Given this list of marker genes WT1-AS, CDIPT (CDP-diacylglycerol--inositol 3-phosphatidyltransferase), GRIN2D, C22orf31, ADAMTS1 (NCBI Gene Id 9510), VCP, CDKN1A, NUDC, ACVR1, STK40, UNC45B, OLFML1, TMEM138, TSBP1, RAB24, EPB41L1, STAT4, EWSR1, FGF16, CDK5R2, JARID2, FBXO30, DNAJB5, BEST3, INTS2, MYOD1, CEP164, ATP6V0D2, TOP6BL, SGMS2, NTF4 (NCBI Gene Id 4909), LRRC17, ZBTB32, TLK1, PRDX6, DNAJB2, RIMS2, MAPT, HAT1, E2F1, MORF4L2, KRT26, SPACA3, CEPT1, TMPRSS11A, MYT1, CXXC4, PLAT, CD274, ATP5ME, KCNH2, C4orf17, HSPH1, CYP39A1, SPTLC3, PNCK, SPATA17, GPX1, PDP1, AZIN1, SLC4A2, LIX1, TWIST2, KRIT1, SAG, NCKAP5, CCN1, KCNQ1, GPATCH2, ESR1, EMX2, RALYL, SELP, CHORDC1, SPMIP6, PWWP3B (NCBI Gene Id 139221), TSPAN6, MTPN, NPPB, IL2, GABRB1, RAB2B, PROM1, NUP98, JMJD6, MEGF10, IER5, STIP1, HMBOX1, WNT3, LYRM1, MGAT3, NRGN, ACOT7, TOP1, HSPB1, STAG2, GTF3C2, CCT4, ZNF436-AS1, EIF5B, TLR8, PTRH2, DCUN1D3, CAP1, FAM106A, TGIF1, TNMD, YWHAG, LGSN, EFHD1, STAMBP, LMOD1, IL34, MED26, IMMP1L, RHBDD3, SERPINH1, TEDC1, ELP4, RNFT1, PPP1R7, SERPINA10, JAG1, UPF2, FLRT1, ETV1, GRK2, PTHLH, IL21R, ABL1, ZNF407, ELOVL1, XPNPEP3, RFTN2, PTGDS, COG7, GJB6, MEIOB, TAS2R5, MLLT11, MAP3K6, PCDH8, EGR2, AIFM3, KRT20, ZNF593, BCL6, ABCA3, PER2, TPP2, PKN1, HSPD1, RTN1, VWA1, IL22RA2, CCDC117, APLP2, C1orf105, AP3D1, NETO1, CYB561A3, KLHL9, CNIH1, BRD2, PRDM2, ABTB3, GPR22, CLDND2, CDK5, HSPB2, CYP46A1, DERL3, DMRTB1, LTC4S (NCBI Gene Id 4056), SIX3, EVC2, ST13, RFLNB, CELF3, CCDC6, CRYAB, YIPF4, HSPA8, ARSG (NCBI Gene Id 22901), PNKD, SDHAF4 (succinate dehydrogenase complex assembly factor 4), MAST1, SATB2 (NCBI Gene Id 80104), CDIN1, RAB18, HSPA9, PAFAH1B2, GSTT4, ARMC12, C8orf17, HNRNPA2B1, TTC9B, SLC35C1, TRA2B, CBX3, ADRA2C, HIKESHI, WBP2, CSTPP1, VMP1, PLSCR4, MXRA8, GOLT1B, GOLGA3, RUNX1T1, CACNA1I, DNAJB4, RPS6KA3, YWHAQ, DAZL, ZKSCAN8, IDH1, GLRA2, KCNAB1, ARHGEF12, PPID, SEMA6A, PDE4C, ATP2C1, QRFP, PRPH, CDR1 (cerebellar degeneration related 1), MYL5, NODAL, GABRA1 (gamma-aminobutyric acid type A receptor subunit alpha1), NT5C3B, PON2, SLITRK2, TBL1XR1, GRHL1, GRB10, UCHL1, PAPOLA, PHF6, GAB2, SEMA3A, INVS, POMGNT1, GPRASP2, AOAH, CNTNAP2, PIK3R1, XPO1, SPA17, HSP90AB1, CCT8, EP300, IRF8, GABRB3, SLC25A27, TMEM255A, C12orf50, HSPE1, DYNLL1, NPR1, NFATC3, CLU (NCBI Gene Id 1191), HORMAD2 (HORMA domain containing 2), SYNCRIP, AGTR2, LGALS8, USPL1, TBC1D10B, UBE2B, SLC2A12, RPS18 (ribosomal protein S18), WASL, MYO19, VPS52, JADE2, GAS7, MAT2A, DNAJA1, PGAP2, TXNDC9, GNA13, INTS9, PARS2, GDPD3, CAMK2B, PASK, SIAE, RECQL, ZDHHC14, LGI1, MAP1LC3B, DNMT3B, FBXO33, FLNC, SOD2, IPCEF1, ACTA1, TAC4, SCN3A, SPIN1, TMC5, KLHL10, ARHGAP6, KDM6A (lysine demethylase 6A), GCNT2, PGM1, MTA2, MEPE, SCGB1A1, SRPK2, CDC42SE1, PDGFB, PPP2R5B, TNFSF15, TMEM50B, GPC4, LRRC1, PRELID1, SEPTIN4, ZNF384, NUP153, BCOR, NPY2R, PDZD7, GLIPR2, CDH22, NNAT, ACSBG2, TMEM33, LGI2, PIGW, DCAF4, PIK3R2, FBXO5, HOXA3, MIR17HG, ACRV1, UBE2W, PIGV, here is a description of the gene set: Comprehensive identification of all functional elements encoded in the human genome is a fundamental need in biomedical research. Here, we present a comparative analysis of the human, mouse, rat and dog genomes to create a systematic catalogue of common regulatory motifs in promoters and 3' untranslated regions (3' UTRs). The promoter analysis yields 174 candidate motifs, including most previously known transcription-factor binding sites and 105 new motifs. The 3'-UTR analysis yields 106 motifs likely to be involved in post-transcriptional regulation. Nearly one-half are associated with microRNAs (miRNAs), leading to the discovery of many new miRNA genes and their likely target genes. Our results suggest that previous estimates of the number of human miRNA genes were low, and that miRNAs regulate at least 20% of human genes. The overall results provide a systematic view of gene regulation in the human, which will be refined as additional mammalian genomes become available. Genes having at least one occurrence of the highly conserved motif M72 TTCYRGAA in the regions spanning 4 kb centered on their transcription starting sites. The motif does not match any known transcription factor binding site. Human Gene Set: TTCYRGAA_UNKNOWN studied in species Homo sapiens from publication Xie X, Lu J, Kulbokas EJ, Golub TR, Mootha V, Lindblad-Toh K, Lander ES, Kellis M (PMID 15735639)